Given this list of marker genes PLA2G4D, PLA2G12B, PLA2G4C, PLA2G2D, PTGS2 (prostaglandin-endoperoxide synthase 2), PLA2G4A, PLA2G12A, PLA2G7, HRAS, PLA2G10, PLA2G4E, PLA2G1B, PLA2G6, TP53, ALOX5, PLA2G5, PLA2G4F, CDKN1A, SLCO2A1, PLA2G3, here is a description of the gene set: Lipid metabolism in senescent cells species: Homo sapiens Human Gene Set: WP_LIPID_METABOLISM_IN_SENESCENT_CELLS